The following is a description of a gene set: Human Gene Set: TRAYNOR_RETT_SYNDROM_UP Genes up-regulated in primary fibroblasts from Rett syndrom patients who carry mutations inactivating MECP2. from publication Traynor J, Agarwal P, Lazzeroni L, Francke U (PMID 12418965) BACKGROUND: Females with the neurological disorder Rett syndrome are heterozygous for mutations in X-linked MECP2 that encodes methyl-CpG binding protein 2 (MeCP2) thought to act as a transcriptional repressor. To identify target genes for MeCP2 modulation, we studied global gene expression in single cell-derived wild-type and mutant MECP2 expressing fibroblast clones with four common mutations (R106W, R306C, 705delG, 1155del32) and in lymphoblastoid cell lines (LCLs) that included four mutant MeCP2 (T158M, 803delG, R168X and 1159del28) expressing, and five (1159del28, R106W, R255X, 803delG, 803delG) wild-type MeCP2 expressing lines. METHODS: Clonality and mutation status were verified by androgen receptor methylation assays for X-inactivation and by sequencing MECP2 transcripts. Expression studies were done with oligonucleotide microarrays (Affymetrix U95) and verified with real-time quantitative RT-PCR using Sybr Green. RESULTS: Expression of 49 transcripts was increased, and expression of 21 transcripts was decreased, in at least 3 of 4 mutant/wild-type fibroblast comparisons. Transcript levels of genes, determined by quantitative RT-PCR, were highly correlated with the microarray data. Therefore, multiple additional clones from two Rett individuals were tested by RT-PCR only. Striking expression differences were found in both mutant and wildtype MeCP2 expressing clones. Comparing expression profiles of lymphoblastoid cell lines yielded 16 differentially expressed genes. CONCLUSIONS: MeCP2 deficiency does not lead to global deregulation of gene expression. Either MeCP2's in vivo function does not involve widespread transcriptional repression, or its function is redundant in cell types that also express other methyl-CpG binding proteins. Our data suggest that clonal fibroblast strains may show substantial inter-strain variation, making them a difficult and unstable resource for genome-wide expression profiling studies. species: Homo sapiens, and this is the list of marker genes: PLA2G4A, MMP10, NTN4, HSPB3, SPON2, CA12, IFI44, CNKSR3, LTBP1, ACKR4, ANKRD29, MMP3, SVIL, BID, IL6, PTGER3, TCF21, AKAP12, FBLN1, C1R, IRX3, PLCB1, RGCC, PRICKLE1, SNTB1, FNIP1, GAPDH, MMP1 (NCBI Gene Id 4312), LRCH2, DNASE1L1, SLC16A7, STAT1, LIMS3, DPP4, GALNT15, PRUNE2, SYTL2, RNF182, TNFRSF19, MOXD1